Given this list of marker genes XPNPEP1, LAP3, NPEPL1, LNPEP, LVRN, NPEPPS, METAP1D, RNPEPL1, METAP1, MMP16, METAP2, MMP14, ERAP2, MMP15, PEPD, ENPEP, AOPEP, XPNPEP3, NPEPPSP1, TRHDE, MMP17, ANPEP, LTA4H, ERAP1, XPNPEP2, RNPEP, here is a description of the gene set: Catalysis of the hydrolysis of a single N-terminal amino acid residue from a polypeptide chain by a mechanism in which water acts as a nucleophile, one or two metal ions hold the water molecule in place, and charged amino acid side chains are ligands for the metal ions. studied in species Homo sapiens Human Gene Set: GOMF_METALLOAMINOPEPTIDASE_ACTIVITY